The following is a description of a gene set: species: Homo sapiens Human Gene Set: GSE4811_CLASSSICALY_ACTIVATED_VS_TYPE_2_ACTIVATED_MACROPHAGE_DN The purpose of this study is to identify novel markers for the type II activated macrophage, which is generated by classical stimulation in the presence if IgG immune complexes. These cells gererally produce high levels of IL-10 and low levels of IL-12, in comparison to classically activated macrophages. We wish to identify gene expression which is enriched in Type II activated macrophages in comparison to classically activated macrophages. from publication Edwards JP, Zhang X, Frauwirth KA, Mosser DM (PMID 16905575) Genes down-regulated in activated macrophages: classically (M1) versus alternative (M2)., and this is the list of marker genes: C4B, TRMT12, ZNF503, PTPRF, DYNLRB2, SDK2, TRPV4, PEG10, SLC38A3 (NCBI Gene Id 10991), BACE2, DTX3L, TMEM51, RNF122, PTPRN, TUB, KRT79, FAM151B (family with sequence similarity 151 member B), GLT6D1, NDFIP2, IL12A, AKAP3, MAZ, UBXN10, ARHGEF28, RGS20, ACTC1 (actin alpha cardiac muscle 1), NTM (NCBI Gene Id 50863), ODF1, ENAM, TAS1R2, ELF3, GRIN1, COLEC10, BPIFB1, TNMD, ABCA9, CTSA, XCR1, CFAP96, PEX5, ZP2, SBSPON, ATP7B, CASR, MATN2, SMOC1, CBLC, TBC1D10C, SH3GL1, CAV3, RNF151, EMC10, PCYT1B, UPF1, SHF, VEPH1, HAL (histidine ammonia-lyase), B4GALNT1 (beta-1,4-N-acetyl-galactosaminyltransferase 1), ACSF2, ZNF169, TEKTIP1, HGFAC, PRODH2, PCNX2, RABAC1, C2, TEKT2, SCN9A, PRAM1, DMRTB1, TMEM203, P3H2, KIF21A, FOSB, PDE4A, IRX3, OPN1LW (NCBI Gene Id 8261), CLEC12B, TGFB2, HIF3A, RAD51D, SPRN, OR7C1, MIXL1, SCARA5 (NCBI Gene Id 286133), ISX, MCRIP1, CADM3, SLC22A17 (NCBI Gene Id 57100), UPK3A (uroplakin 3A), SPOCK1, MUC16, ABCB4, KCNJ12, GFRA4, TTLL9, RIMKLB, PDCD6, TCL1A, SMKR1, FCGRT, AGT, ACAD10, ALX3, DIRAS2, SPINK8, VAMP1, AIRE, IRGC, SH3RF3, ELANE, SLC7A8, LRRC10B (NCBI Gene Id 390205), PDZK1IP1, DBNDD1, TNS2, ZAN, TNFAIP3, FXYD4, GLMP, CYP2W1, POM121L2, SCGB3A2, CFAP410, UBE2G2, SRY, KIT (KIT proto-oncogene, receptor tyrosine kinase), GPC3, CCIN, ZNF227, SNAPC4, GATA6 (GATA binding protein 6), NECTIN4, PITX2, TTN, TFF2, TMEM269, GDAP1L1, CCDC80, RPL4, BEX2, TAS1R1, AMER2, ASPN, CD34, ARIH2OS, GARNL3, GLP1R, GPR37, KCNK12, SLC6A2, KCNJ5, LIX1, TCN2, CD209, XK, DZIP1L, TAFAZZIN, LRRN1, FGF21, HOXA9, PDE7A, ABCG5, ADRB3, RASAL1, HOXC10, MEIKIN, KPRP, DCT, KLC2, ANKLE2, POU3F2, FOXD3, HS3ST6, SPNS2, TNPO2, AVIL, ALPK1, TMEM60, SERPINH1, ENTPD6, QRFPR, MATN4, CCDC125, TXNL4A, EXOSC6, PDGFRL, MCF2L, SLC17A3, GALNT18, BBOF1, TOR1AIP1, NXPH3 (NCBI Gene Id 284079), DLG4, TTR, GPR101, FTMT, CALY (calcyon neuron specific vesicular protein), MYH2, GAST